The following is a description of a gene set: Genes having at least one occurrence of the highly conserved motif M22 TGCGCANK in the regions spanning 4 kb centered on their transcription starting sites. The motif does not match any known transcription factor binding site. studied in species Homo sapiens from publication Xie X, Lu J, Kulbokas EJ, Golub TR, Mootha V, Lindblad-Toh K, Lander ES, Kellis M (PMID 15735639) Human Gene Set: TGCGCANK_UNKNOWN Comprehensive identification of all functional elements encoded in the human genome is a fundamental need in biomedical research. Here, we present a comparative analysis of the human, mouse, rat and dog genomes to create a systematic catalogue of common regulatory motifs in promoters and 3' untranslated regions (3' UTRs). The promoter analysis yields 174 candidate motifs, including most previously known transcription-factor binding sites and 105 new motifs. The 3'-UTR analysis yields 106 motifs likely to be involved in post-transcriptional regulation. Nearly one-half are associated with microRNAs (miRNAs), leading to the discovery of many new miRNA genes and their likely target genes. Our results suggest that previous estimates of the number of human miRNA genes were low, and that miRNAs regulate at least 20% of human genes. The overall results provide a systematic view of gene regulation in the human, which will be refined as additional mammalian genomes become available., and this is the list of marker genes: XRCC2, SNRNP70, MAP4K3, SRRM2, BTBD3, SYNGR4, TNKS2, SDCCAG8, ABHD13, BDNF, DAW1, BRINP3, ZBTB4, ZMAT3, CTCFL, RAB18, ANGPT1, CDC5L, HSPB9, TOLLIP, SPRY4, PDE4D, AIFM1, KCTD13, DCTN5, HR, MORF4L2, PABIR2, MTRFR, OARD1 (O-acyl-ADP-ribose deacylase 1), CKLF, KLHL7, TCTA, ARRDC3, VPS13C, TRIM46, RNF38, PTGES3, SNRPN, TENT2, SENP7, ZNHIT1, DNAL1, SNRPD2, FLYWCH2, ARSK, COG6 (component of oligomeric golgi complex 6), TMTC1, EIF2B5, MXD3, RAB23, GTF2A1, PPP1R15B, CEP85, TMEM143, DYNLT1, C6orf136, CCNG2, RPL14, TRAM1L1, ZCWPW1, ATF7IP, THAP12 (NCBI Gene Id 9137), C11orf71, HMMR, SKIC3, QPCTL, CCNI, CNOT4, TDRD1 (tudor domain containing 1), RTBDN, POP7, TRAM1, PSD, ARL3, RSRC1, MEA1, PPP1R12A, RELA, UTP11, HINT1, ERG28, RHOA, TMEM179, VSNL1, SRPK1, KRTCAP2, TMEM255A, GABRB2, DNAJB12, BANP, C14orf178, CDC7, NUDT11, NRF1, MAGED1, CA11, SLU7, KANSL1L, POLR2B, HNRNPA2B1, SNURF, NUDCD2, DYNLRB1, RBM7, CDK16, HTN1, PABIR1, MECP2, GPX4 (glutathione peroxidase 4), HPCA (NCBI Gene Id 3208), TCF25, REPIN1, MAPKAP1, ZMYM6, CENPO, HOXA1, GLRA2, VCPIP1, JAKMIP1, PLEKHA1, RALGAPB, EIF3E, EMC10, JADE2 (NCBI Gene Id 23338), ZNFX1 (zinc finger NFX1-type containing 1), RBPJ, ELOVL4, AP1S1, ZMYM4, RAB1B, AQP11, SMARCA5, IRAK4, PSPC1, MTFR1, BCL9, DAD1, CHMP5, RPL7L1, BAG1, DLEU1, CTDSPL2, PCDHGB6, GOPC, RPS16, OSR1, TRAPPC12, MRPS18B (mitochondrial ribosomal protein S18B), ABHD14A, TFAP4, TBC1D32, LINC01106, SRSF2, RANBP3, ATP6V1F, SLC35A5, PTS, PCGF1, WDTC1, PPARGC1B, HEATR3, LSM8, COX7A2L, WNT5A, DLEU2, CIZ1 (CDKN1A interacting zinc finger protein 1), NAE1, PHF1 (NCBI Gene Id 5252), CBX5, TOB2, EIF4A2, RBM14, CRK, MPC2, FGF12, KAT2A, FXR2, SLC9A7, ZBTB5, RASGEF1A, EIF1, UBA52, TOMM7, FOSB, KMT2A, ACOT13 (acyl-CoA thioesterase 13), USF2, PTPN12, MED11, FAM13B, MCRS1 (NCBI Gene Id 10445), PCDH7, BRK1, KIFAP3, NCOR1, LENG8, ADGRB3 (NCBI Gene Id 9664), CCDC106, POU2F1, FANCL, MEPCE, RAB10, PMS2, SF1, METTL22, PPTC7, DMD (dystrophin), POLR2A, HS3ST3B1, PFDN1, KAT7, ZBTB21, PRDX3 (NCBI Gene Id 29017), PNRC1, PKMYT1, EIF5A, ATAD3A, ESRRA, ZNF334, RPL5, SLC6A7, RPL19, PCIF1, RFXANK, FGF9, ZNF248, EID2B, BMERB1, HOOK3, KCNN2, KIFC2, TAF5, CCDC97, ZNF668, BCL7A, GFI1, PRICKLE4, COPS5, GABRA4, AIP, LPCAT3, RABGGTB, FMC1, DAAM1, KLHDC3 (kelch domain containing 3), PPP4R4, AFF4, NOL4, CHMP2B, KDM5C, TIA1, MSH2, OTUD5, MRPL45, PTMA, RABIF, PIM2, SMARCA4, LIPT2-AS1, KIF9 (NCBI Gene Id 64147), LSM12, KDM3A, OTX2, NEURL1, PLOD3, SNW1, ZC3H8, KCNK5, GATD3, DOK6, HOXC6, ZFTRAF1, SFXN2, AGO1, RETREG3, RAB35 (RAB35, member RAS oncogene family), RPS6KB1, TXLNG, NUDT10, WDR53, B3GALT2, MTPN, RNF19B, PDE7A, TP53I11, SIKE1 (NCBI Gene Id 80143), E2F6, SLC2A4, PKIB, PNN, TMED4, IMMT, COPG1, TSACC, PACRG, SERINC1, TXNDC11, NR2F2, PIGL, FKBP2, SLC12A5, FBXO9, PUS7L (NCBI Gene Id 83448), TRMO, PPP1R10, EID2, SRR, NR1D1, IPO9, HOXC4, TEF (NCBI Gene Id 85370), WDR44, CACUL1, DMRTB1, IFT27, REEP3, ZNF287, P4HA1, TSEN2, TMX1, ZNF646, EIF3K, SDHA, UPF2, NFYA, ANGEL2, TGIF1, EWSR1, NDUFA6, PAQR4, PCBP2, ARHGEF15, DDX3X, RPP38-DT, ABHD14B, UBE2K, CALM3, CAPN5, CBX3, TDP2, SAFB (NCBI Gene Id 6294), SRSF5, CD47, NFKBIA, MIB1, MLH3, ZNF585B, SPRED1, MRI1, NR2C1, ZNF565, PALB2, FAM222B, PNMA8A, PDIA5, CKS2, EEF1AKMT1, SHISA7, RHBDD3, CCT3, PCSK2, SEC23IP, DENND5A, RNF170, NNAT, VAPB, CNOT9, DNMT1, CBX4, MRPL22, AKIRIN2, GPATCH11, ADCK5, PSMA2, B9D1, RNF24, DPY30, GFOD2, C2CD6, SENP3, FRS3, CNBP, RAD21, IGF1, NUDT9, WWP1, NONO, ZNF503, HEXIM2, PPME1, TTLL1, RPS6KA5, ALG9, EED, OGA, HDX, XIAP, EIF4G2 (eukaryotic translation initiation factor 4 gamma 2), ASRGL1, TUBG2, POLA1, SCN3B, CNKSR2, NXF1, ZNF575 (NCBI Gene Id 284346), CREB1, SNRNP35, ZNF653, HACD3, AIMP2, ORC4, GGNBP2, ACTR1A, EIPR1, WDR12, CARF, CLIP3 (CAP-Gly domain containing linker protein 3), STRADA, NAA25, ZGRF1, GABRB1, TECR, ZBTB43, RBFOX1, NDUFB8, GPD1L, SMG6, ARSB, MTFMT, EIF2S2, INPP5F, MSL2, ATAD3B, YWHAE, KLHL10, RNF32, SRSF7, KMT2E, WDR20, PSMA4, POU4F2, VRK3, SLC25A31 (solute carrier family 25 member 31), PRKN, ING2, ICMT-DT, CYB561D2, ZNF12, AOPEP, SMARCB1 (SWI/SNF related, matrix associated, actin dependent regulator of chromatin, subfamily b, member 1), FOXO4 (NCBI Gene Id 4303), DTX2, MAP2K6, MYCBP, MAGED2, NDRG1, KLHL18, SELENOI, GRIA3, LEP, AP2B1, CDKAL1, NUMB (NCBI Gene Id 94910), NCOA5, SPOP, GTF3C1, HERC4, NDEL1, ARVCF, VAT1 (NCBI Gene Id 10493), MRPL32, USP37, ELAVL4, ZNF382, MAP4K1, FLT4, ARMC8, MEF2B, XRCC5, SAE1, HNRNPL, ICMT, USF1, RPP38, PCGF6, ACP1, RCL1, CAB39 (NCBI Gene Id 51719), DNM1, MINK1, C2CD2L, SSH2, PRIMA1, COQ2, MAPRE3, ARL6IP4, COQ3, SUFU, SWT1, RNF32-DT, THRA (NCBI Gene Id 7067), RBM24, TDRD5, CDK2AP2, GGN, RASA1, GPRASP2, U2AF2, PINK1, CTBP2, EPS15L1, ARRB2, TXNDC12, HNRNPH1, SHPRH, RILPL1, DNAJA2, UBE2M, HNRNPA1, MRTFB, MAP2K7, PCSK1N, LRP1, NOA1, XRCC1, NPRL2, PDXDC1, CAVIN1 (NCBI Gene Id 284119), SYT12, TUBG1, TBCCD1, FAM98A, TRMT1L, PABPC1, TUBD1, SPAG8, PCYT2, DVL2, NT5C3B, CSTF1, AURKA, TMEM39A, SRSF1, KIF3A, FAM174A, DLD, PREB, RALBP1, FAM120C, ASB8, POLI (NCBI Gene Id 11201), CCDC127, SRRM1